The following is a description of a gene set: species: Mus musculus Establishment of the epithelial barrier, the functional barrier in the skin that limits its permeability. Mouse Gene Set: GOBP_ESTABLISHMENT_OF_SKIN_BARRIER, and this is the list of marker genes: Zfp750, Grhl1, Flg2, Lsr, Il18, Tmprss13, Abca12, Kdf1, Cldn1, Tmem79, Ugcg, Srf, Met, Krt1, Cldn4, Gak, Krt16, Hdac3, Nfkbiz, Hrnr, Ncor2, Alox12b, Grhl3, Cysrt1, Klf4, Cldn13, Elovl1, Aloxe3, Gba1, Tmprss11f, Ncor1, Trp63, Fa2h, Kprp, Cdh1, Dsc1, Alox12, Cyp26b1, Plec, Pnpla1, Stard7, Sfn, Stmn1, Flg